The following is a description of a gene set: Genes having at least one occurence of the motif CTTGTAT in their 3' untranslated region. The motif represents putative target (that is, seed match) of human mature miRNA hsa-miR-381 (v7.1 miRBase). Human Gene Set: CTTGTAT_MIR381 species: Homo sapiens, and this is the list of marker genes: CACNA1C, MED13L, MBNL2, ANKS1B, MITF, MFSD14B, NAP1L5, KIF1B, PAPOLG, JAG2, SCAF8 (NCBI Gene Id 22828), APPBP2, GAD1, KCTD15, PRMT6, TBC1D15, GJA1, RALGPS1, MEIS2, CARMIL3, PARD6B, EIF3A, FAM117A, ZBTB22, NFKBIA (NCBI Gene Id 4792), BCL11B, TCHP, MPHOSPH9, RC3H1, NIN, ACSL3 (NCBI Gene Id 55484), FOXF2, STX12, SEPTIN11, PMP22, EPHA4, UBR5, ZMYND11, EPB41L1, KLF12, KHDRBS1, PAN3, PPP4R3B, SOX4, UBR3, KCTD3, GID4, SIPA1L2, MAP4, PRPF38B, PNRC1, AZIN1, UBE3A, ROCK2, RPS6KA3, NDUFAB1, BRD7, RPS6KB1, NAV3, PRDM12, JPH1, SHANK2, CLIP3, UBR1, PDS5A, JADE2 (jade family PHD finger 2), LRRC4, ST8SIA2, NRXN1, VSNL1, ETF1, SYNCRIP, AGPAT3, NLK (nemo like kinase), LCOR, PURG, ADGRL1, DLC1, PDS5B, DCUN1D3, SATB1, WNT5A, SLC6A8, SIAH1, KALRN, LARP1, OSBPL3 (NCBI Gene Id 26031), MSL2, NHS, PRRC2A, EIF1, LZTS2, CGGBP1, B3GNT5, RNF2, FLRT3, RAP2C, CREBRF, EPHA3, PDAP1, UBE4A (NCBI Gene Id 9354), CHD4, KLF4, MED14, UBE2E2, ZFAND3, FCHO2, GORASP2, PHF2, RBSN, HNRNPR, CDK2AP1, NAMPT, CLCF1, ARPP21, YTHDF1, MECOM, RNF13, DHX40 (DEAH-box helicase 40), SLMAP, CSTF3, NEXMIF, RAB2A, MTSS1, NFIA, KANSL1, GFRA1, EIF4G2, VCPIP1, HIPK1, NR5A2, MED13, EPB41, RETREG3, RAB11FIP2, ASXL2, RNF144A (ring finger protein 144A), RHOQ, ANO4, XPO7, PTBP3, NBEA, DDX6, SRRM1, ANKRD50, RPL35A, GRM8, CXCR4, GRM1, CDIN1, KPNA3, EIF4G3, WAPL, SLC38A2, SEMA6D, ANKRD12, SSH2, UBN1, HNRNPH2, BTBD7, SNRK, TRIM63, PAPOLA, BCL11A (NCBI Gene Id 55085), ABRAXAS1, ARGLU1, ELOVL7, ABCA1, PSIP1, BHLHE22, R3HDM2, BIRC6, RNF111, ZFPM2, ZNF532, IQSEC2, ATRN, WEE1, RRAGB, CCNT2, CEBPA, SLC24A3, ACVR2A, ZNF770, GTF2I, COL3A1, CNOT7, SEMA3C, PDGFC, HMBOX1, SNRNP40, HBP1, ACTG1, R3HDM1 (R3H domain containing 1), TUT4, QKI, GAS2, ETS1, ITCH, TLN2, ARID4B, LURAP1L, STAG1, INSIG1